Given this list of marker genes SHLD1, MAP3K7, STAT6, NSD2, EPHB2, TNFSF13, LAPTM5, IL1R1, TGFB1, SPON2 (NCBI Gene Id 10417), PANX1, DENND1B, RIGI, CLNK, TNFRSF4, IL10, KIT, PGC, TLR4, IL18, SHLD3, BTK, TICAM1, CLCF1, LACC1, FFAR2, RIF1, GATA3, INAVA (NCBI Gene Id 91162), DDX21, CD86 (CD86 molecule), SYK, PAXIP1, CD226, DEFB131A, TRAF2, TLR3, IL13RA1, CD55, SEMA7A, IRF5, VAMP3, IL17F, RAET1G, FZD5, CD74, IL13, TLR9, P2RX7, MLH1, HLA-G, CD7, WNT5A, IL6, DHX36, NOD1, CD160, KLK7, CARD9, KMT5C, RIPK2, IL4R, SPHK2, CD36 (NCBI Gene Id 948), FFAR3 (free fatty acid receptor 3), TRIM6, STX4, PHB1, IL2RG, RSAD2, TFRC, TNFSF4, EXOSC3, RTN4, TBX21, TP53BP1, HTR2A, HK1, TLR7, XCL1, MIF, SCIMP, DNAJB9, PMS2, CD40, MAD2L2, GPRC5B, IL2, IL33, IL5, SLC7A5, CD81, RBP4, CD37, TNFRSF14, PYCARD, MZB1, PRKCZ, PLCG2, NLRP3, NR4A3, MAPKAPK2, HMCES, CLEC7A, SASH3, IL1B, IL18R1 (interleukin 18 receptor 1), ATAD5, NOD2, SLAMF1, CAMK4, C17orf99, GPI, MALT1, MAVS, KIR2DL4, CD244 (NCBI Gene Id 51744), SIRT1, KMT5B, MYD88, FCER1G, KLK3, MSH2, HLA-E, TRAF6, DDX1, HLA-A, ARID5A, SHLD2, IL4, IL21, GALNT2 (polypeptide N-acetylgalactosaminyltransferase 2), B2M, PHB2, IL17A, HLA-F, KLK5, SECTM1, EXOSC6, LILRB1, CD28, HPX, F2RL1, XBP1, PTPRC, BCL10, here is a description of the gene set: species: Homo sapiens Human Gene Set: GOBP_POSITIVE_REGULATION_OF_PRODUCTION_OF_MOLECULAR_MEDIATOR_OF_IMMUNE_RESPONSE Any process that activates or increases the frequency, rate, or extent of the production of molecular mediator of immune response.